Given this list of marker genes Junb, Jun, Hspa1a, Tsc22d3, Hspa1b, Fos, Klf2, Klf6, here is a description of the gene set: Mouse Gene Set: CUI_T_CELL_CD8_BAFF_RESPONSE_DN Cytokines mediate cell-cell communication in the immune system and represent important therapeutic targets. A myriad of studies have highlighted their central role in immune function, yet we lack a global view of the cellular responses of each immune cell type to each cytokine. To address this gap, the authors created the Immune Dictionary, a compendium of single-cell transcriptomic profiles of more than 17 immune cell types in response to each of 86 cytokines (>1,400 cytokine-cell type combinations) in mouse lymph nodes in vivo. A cytokine-centric view of the dictionary revealed that most cytokines induce highly cell-type-specific responses. For example, the inflammatory cytokine interleukin-1β induces distinct gene programmes in almost every cell type. A cell-type-centric view of the dictionary identified more than 66 cytokine-driven cellular polarization states across immune cell types, including previously uncharacterized states such as an interleukin-18-induced polyfunctional natural killer cell state. studied in species Mus musculus from publication Cui A, Huang T, Li S, Ma A, Pérez JL, Sander C, Keskin DB, Wu CJ, Fraenkel E, Hacohen N (PMID 38057668) Genes negatively differentially expressed in cell type: CD8+ T cell upon treatment with cytokine: BAFF in mouse lymph nodes in vivo.